The following is a description of a gene set: The sequence of reactions by which arginine is synthesized from ornithine, then cleaved to yield urea and regenerate ornithine. The overall reaction equation is NH3 + CO2 + aspartate + 3 ATP + 2 H2O = urea + fumarate + 2 ADP + 2 phosphate + AMP + diphosphate. Human Gene Set: GOBP_UREA_CYCLE studied in species Homo sapiens, and this is the list of marker genes: SLC25A15, CEBPA, NAGS, CPS1, ARG2, FH, AGMAT, ASS1, ARG1 (arginase 1), SLC25A2, OTC, ASL